Given this list of marker genes LAMTOR3, RPL37A, RPL22, CEBPB, RPL24, MIOS, EIF2AK4, RPS4X, 18S rRNA, RPL11 (ribosomal protein L11), RPTOR, RPL5, RPL8, LAMTOR2, RPL37, RPS27A, RPL14 (ribosomal protein L14), ATP6V1D, RPS24, RPL18, SLC38A9, SESN1, RPL3, 5.8S rRNA, CASTOR1, RPS10, ATP6V1G1, RPL29, 28S rRNA, RPS6, RPS23, DEPDC5, RPS17, RPL35A, RPL10L, EIF2S3, RPL27, IMPACT, RPL15, ATF2, ATP6V0D1, ASNS, SEC13, RPL10A, ATP6V1F, RPL35, RPL27A, RPS25, ATP6V1A, NPRL2, EIF2S1, NPRL3, DDIT3, RPL36A, ATP6V1H, RPL17, RPL13, 5S rRNA, RPS11, CEBPG, KPTN, RPLP2, ATF3, RPS5, RPL39, RPLP0, RPSA, RPL19, RPL36, RPL34, RPS2, RPS4Y1, RPL32, RPL13A, RPL18A, UBA52, RPL39L, TCIRG1, RRAGD, TRIB3, ATP6V1G2, RPS29, RPL6, ATF4, RPL9, SEH1L, MLST8, RPL7, RPL26L1, ATP6V0B, RPS18, RPS27, ATP6V0E1, RPLP1, ATP6V1B1, FAU, RPS3, RPL36AL, WDR59, ITFG2, WDR24, LAMTOR4, ATP6V0E2, RPL22L1, RPS26, KICS2, GCN1, FLCN, RPL28, EIF2S2, RPS16, ATP6V0D2, RPL21, FNIP2, RRAGC, RPL26, RPS27L, RPS7, RPS15A, LAMTOR5, LAMTOR1, RHEB, ATP6V1E1, RPS19, FNIP1, RPS21 (NCBI Gene Id 6227), SZT2, RPS13, CASTOR2, RPS12, RPL23A, ATP6V1G3, SAMTOR, SH3BP4, RPL38, RPS9, RPL30 (ribosomal protein L30), RPS4Y2, RPL4, RPL7A, RPL41, RPS3A, MTOR, RPS20, ATP6V1C2, ATP6V0C, RPS14, RRAGA, RPS15, ATP6V1E2, ATP6V1C1, RPL3L, RPS8, RPS28, SESN2, RPL10, RPL31, RRAGB, RPL23, ATP6V1B2, RPL12, here is a description of the gene set: Deprivation of nutrients triggers diverse short- and long terms adaptations in cells. Here we have annotated two aspects of cellular responses to amino acid deprivation, ones mediated by EIF2AK4 and ones mediated by mTORC.<br><br>EIF2AK4 (GCN2) senses amino acid deficiency by binding uncharged tRNAs near the ribosome, and phosphorylating EIF2S1. This reduces translation of most mRNAs but increases translation of mRNAs, notably ATF4, that mediate stress responses.<br><br>The mTORC1 complex acts as an integrator that regulates translation, lipid synthesis, autophagy, and cell growth in response to multiple inputs, notably glucose, oxygen, amino acids, and growth factors such as insulin.<br><br>MTOR, the kinase subunit of mTORC1, is activated by interaction with RHEB:GTP at the cytosolic face of lysosomal membrane. This process is regulated by various individual amino acids and is reversed in response to the removal of amino acids, through the action of TSC1. part of: Cellular responses to stress species: Homo sapiens Reactome Pathway: Cellular response to starvation